The following is a description of a gene set: Human Gene Set: PID_ERBB_NETWORK_PATHWAY species: Homo sapiens from publication Schaefer CF, Anthony K, Krupa S, Buchoff J, Day M, Hannay T, Buetow KH (PMID 18832364) ErbB receptor signaling network, and this is the list of marker genes: AREG, HBEGF, EREG, NRG1, NRG2, BTC, ERBB4, TGFA, ERBB3, HSP90AA1, NRG3, EGFR (NCBI Gene Id 1956), NRG4, ERBB2, EGF